The following is a description of a gene set: species: Homo sapiens Noncanonical activation of NOTCH3 Human Gene Set: REACTOME_NONCANONICAL_ACTIVATION_OF_NOTCH3, and this is the list of marker genes: PSEN1, APH1B, NOTCH3, APH1A, YBX1, PSENEN, NCSTN, PSEN2